Given this list of marker genes GJA5, TUBB4A, FLCN, RPS6KA3, HNF1A, VHL, PSEN1, RNF139, NPAP1, MAPT (microtubule associated protein tau), SNORD116-1, HNF1B, NR4A2, UBE3A, SNCAIP, MEF2C, HERC2, JAK2, SIX3, KRAS, RPS14, EHMT1, SUMO1, SIN3A, SNRPN (small nuclear ribonucleoprotein polypeptide N), STX16, TSHR, MAGEL2, ALDH18A1, KIT, TSC2, MKRN3, RB1, ADH1C, IGF2, ADA2, GNAQ, CTBP1, GJA8, PWRN1 (NCBI Gene Id 791114), EP300 (E1A binding protein p300), SKI, PDGFRA, CACNA1S, ZBTB20, GNAS-AS1, FGFRL1, RAI1, COQ2, FGFR1, TINF2, GNAS, SPECC1L, NRAS, CPLX1, ATXN3, GBA1, NIPBL, MAP2K1, NSD2, HRAS, PTDSS1, IRF6, FOXG1, ALX3, LMNB2, PWAR1, KIF1B, OGG1, BCL10, FLNB, NLGN4X, GLI2, TBP, SNORD115-1, MYC, AKT1, STK11, ACAT2, FGFR3, NFIA, MTOR, CHD7, CDON, NFIX (nuclear factor I X), TSC1, LETM1, PBRM1, SDHB, SHANK3, HLA-DRB1, ATXN2, MT-TT, SDHC, CREBBP, PIK3CA, ATXN8OS, PAFAH1B1, DRD5, here is a description of the gene set: Human Gene Set: HP_SPORADIC Cases of the disease in question occur without a previous family history, i.e., as isolated cases without being transmitted from a parent and without other siblings being affected. Sporadic studied in species Homo sapiens